The following is a description of a gene set: Cytokine-activated STAT proteins dimerize and bind to high-affinity motifs, and N-terminal domain-mediated oligomerization of dimers allows tetramer formation and binding to low-affinity tandem motifs, but the functions of dimers versus tetramers are unknown. We generated Stat5a and Stat5b double knock-in (DKI) N-domain mutant mice that form dimers but not tetramers, identified cytokine-regulated genes whose expression required STAT5 tetramers, and defined consensus motifs for dimers versus tetramers. Whereas Stat5- deficient mice exhibited perinatal lethality, DKI mice were viable, indicating that STAT5 dimers were sufficient for survival. Nevertheless, STAT5 DKI mice had fewer CD4+CD25+ T cells, NK cells, and CD8+ T cells, with impaired cytokine-induced proliferation and homeostatic proliferation of CD8+ T cells. DKI CD8+ T cell proliferation following viral infection was diminished and DKI Treg cells did not efficiently control colitis. Thus, tetramerization of STAT5 is dispensable for survival but is critical for cytokine responses and normal immune function. Human Gene Set: GSE36888_UNTREATED_VS_IL2_TREATED_STAT5_AB_KNOCKIN_TCELL_17H_DN studied in species Homo sapiens from publication Lin JX, Li P, Liu D, Jin HT, He J, Ata Ur Rasheed M, Rochman Y, Wang L, Cui K, Liu C, Kelsall BL, Ahmed R, Leonard WJ (PMID 22520852) Genes down-regulated in STAT5 double knock-in T cells: control versus IL2 stimulation for 17h., and this is the list of marker genes: GMIP, CAPN3, CHST11, POGLUT3, MAGED1, CPE, AIDA, C2CD4B, SRCAP, MAF, PLEKHG1, REXO2, RNF32, TBL1X, TUBG1, IRAK3, SMPD2, ARRB1, SELENOP, PON2, CNOT2, ROM1, FFAR2 (free fatty acid receptor 2), USP31, SLC9A5, RHOBTB1, RFC5, LMO1, KLHL24, EXOG, CAD, WDR13, SYMPK, MSH2, STK24, SH3BP5, EGLN3, PI4KA (NCBI Gene Id 5297), TWNK, PRICKLE1, CARD10 (caspase recruitment domain family member 10), FBXL6, PNP, USP15, ACOT11, SPNS1, AGTR1, RBM34 (RNA binding motif protein 34), SLC22A17, TAGLN2, CCR7, PUM1, PABPC1, AAGAB, CLCN6, SHMT2, SPOCK2, PLIN3, SEC14L1, DUSP4, ITGB7, TNFRSF21, AHSP, TREML2, NXNL2, DOP1A, CYP27A1, TTC3 (tetratricopeptide repeat domain 3), MEIOC, BTBD1, S1PR1 (NCBI Gene Id 51546), MYO1E, GNB4, LPCAT3 (NCBI Gene Id 10162), PFKP, XKRX, ABLIM3, FKBP5, PTGES3, PLOD1, IQCF1, H19, TSPAN3, PPCS, FUT9 (NCBI Gene Id 10690), SPTAN1, CORO2B, TLE3, GZMA, RASA4, ISLR, TAF6, MFSD2B, IQCH, EXOC4, DRG2, FAM110A, EPAS1, ACOT9, MPPED2, LARP1, FLRT2, TAF13, ALDH7A1, SIK1, SARAF, SELENOT, ART4, RNMT, TRAPPC6A, LTA, TOP2B, FAM53C, AKAP5, LUC7L, RNASET2, STEAP4, SMOX, RAMP1, GZMM, FGD6 (NCBI Gene Id 55785), HK2, C12orf75, YES1, CERS3, TFAP4, SNRNP70, RMND5B, PARK7, NOVA1, ANKRD6, SOX13, APPL2, HIRIP3, ENG, SNX2, HEY1, BRI3BP, TSPAN14, CDC25B, STAB2, ATOH8, CCL4, CISD1, DHCR24, KLF4, KCNC1, PIEZO1, WDR26, CD8B, AKIRIN1, ZFTA, BHLHE41 (NCBI Gene Id 79365), PARP1, NOP16, ANXA6, CCT5, FLT4, POU5F2, CREB3L1, MCMBP, APOBEC2, ICOS, TPD52, CCDC6, IRAK2, UBE2T, CANX, CCT3, QTRT1, LPCAT2, ZFR, MYADM, CLDND1, FAM13B, RAMP3 (receptor activity modifying protein 3), ACSBG1, RIPOR2, SCP2, GSTO1, LTB4R, TLR1, SVIP, NIPAL3, AGPAT5, DGAT1, PRSS54, TNFRSF25, MCUR1, DHRS3, USP7, CSAD, PSTK, DNAJB14, IFT81, RAPGEF3, GALNT1, CACNA1C, KCNK6